The following is a description of a gene set: from publication Chen Y, Wang X (PMID 31504780) Genes predicted to be targets of miRBase v22 microRNA mmu_miR_467f in miRDB v6.0 with MirTarget v4 prediction scores > 80 (high confidence targets). Mouse Gene Set: MIR_467F species: Mus musculus, and this is the list of marker genes: Mapk1, Dmxl1, Lrch2, Atp10b, Ube2h, Rab3c, Cdkl4, Rab11fip3, Tnfrsf11b, Lrrn1, Rab10, Fam43a, Dicer1, Zfp872, Uty, Olfml2b, Mef2d, Rab11fip2, G2e3, Smo, Plekhm3, Chp1, Tcerg1l, Pik3c3, Xrn2, Klhl2, Zbtb41, Foxf2, Hmga2, Rictor, Npat, Pabir2, Rab9, Lrp6, Lrp1b, Rabgap1, Septin9 (septin 9, NCBI Gene Id 53860), Extl3, Smad7, Paip1, Igfbpl1, Tmtc2, Dlat, Wdfy3 (NCBI Gene Id 72145), Hmgxb4, Gfra2, Mmp11, Ccdc82, Fam184a, Zfyve21, Far1, Prkaa1, Parg, Mex3d, Arid4b, Elf3, Gabrb2, Mtfp1, Golph3l, Slc1a2, Ppp4r2, Usp42, Psph, Ulk1, Gucy1a1, Cep192, Hexim1, Usp9x, Naa15, Appl1, Slc28a3, Raph1, Seh1l (NCBI Gene Id 72124), Herc1, Rbfox1, Pitx2, Bbx, Zswim6 (zinc finger SWIM-type containing 6), Snrk, Klf6, Chic1 (cysteine-rich hydrophobic domain 1), Arap2, Hmcn1, Itsn1, Tgfb2, Syt1, Slfn9, Cep135 (NCBI Gene Id 381644), Paics (phosphoribosylaminoimidazole carboxylase, phosphoribosylaminoribosylaminoimidazole, succinocarboxamide synthetase), Secisbp2l, Ube3c, Wee1, Plag1, Zmym6, Clip1, Twist2 (NCBI Gene Id 13345), Trappc10, Ppid, Usp32, Npas3, Tmcc1, Tent4b, Mgam, Nt5e, Fhip2a, Spin1, Rbfox2, Btaf1, Ralgds, Zc3h7b, Pabpc5, Baz2b, Tmem196 (NCBI Gene Id 217951), Zmat1, Ubr1, Zfp871, U2surp, Zfp941, Pde3a, Cxcl16, Mtf2, Ifi204, Dagla, Ogfrl1, Prr12, Ube2d2a, Igfbp1, Cdkn1b, Pigc, Cilk1, Cflar, Gucy1b1, Mapk6, Col1a1, Tle1, Tmprss12, Clstn1, Nova1, Hhip, Cnep1r1, Ube2b, Enpp2, Gorab, Aak1, Mllt10, Nr1d2, Smad6, Zfp280d, Dnali1, Arhgef18 (NCBI Gene Id 319493), Abcd3, Rasef, Cep76 (NCBI Gene Id 76151), Yy1, Hsp90b1, Pde4dip, Tmem33, Eif5b, Adamts5, Tshz3, Slc6a19, Morf4l1, Kcna2, Ino80d, Mrps14, Nedd9, Tecrl, Scp2, Mmd, Mon2, Spock3, Fgfr1, Ctsc, Mcu, Casp8ap2, Vkorc1l1, Rtn1, Pcdh18, Cab39, Ms4a4b, Nfat5, Dgkd, Tsc22d2, Pcdh17 (NCBI Gene Id 77386), Tcf7l2 (NCBI Gene Id 21416), Eif1ad8, Zfp711, Cdh4, Cnot7, Cdc73, Dio3, Txndc9, Trim23, Fbxl17, Nup133, Acyp1, Hectd2, Tasp1, Phf13, Gpm6a, Rbm5, Agtr1b, Kmt2c, Ascl1, Hycc2, Scn2a, Sdad1, Arid1b, Gpr22, Sall3, Rmnd5a, Pkp1, Sdc2, Spred1, Slc38a2, Adamts15, Sfpq, Usp28, Rbbp6, Usp34, Pramel60, Serpini1, Golim4, Lemd3, Eif3e, Stxbp3, Slain2 (SLAIN motif family, member 2), Ddx21, Cast, Synj1, Hnrnpr, Erf, Rb1cc1, Adgrd1, Tc2n, Tle4, Eea1, Pdgfc, Pramel48, Hivep1 (NCBI Gene Id 15271), Homer1, Ctla4, Zfyve16, Jag1, Foxn2, Kdm3a, Grb2, Cks2, Map2, Cabcoco1, Plekhd1, Olr1, Birc6, Tmem170b, Lrif1, Arhgef9, Mbip, Mbnl2, Kif27, Golt1a, Ssbp2, Sbno1, Sh2d4a, Fpgt, Adgre4, Tbr1, Kitl, Fli1, Ss18l1, Hspa14, Pdha1, Fbxo34, Cwc22, Atp2b3, Pcsk2 (proprotein convertase subtilisin/kexin type 2), 1700010I14Rik, Usp25, Rbm27, Malt1, Pum1, Epha5, Lamtor3, Ubtf, Zfp11, Pde3b, Col19a1, Snap29, Slfn8, Myt1l, Pitpnb, Cggbp1, Zfp422, Cxadr, P2ry1, Sh3gl3, Adam9, Pex3, Txlng, Slc10a4-ps, Prkar1a, Hip1, Or51l4, Rras2, Rab14, Casz1, Magel2, Mrpl44, Zic4, Nus1, Arhgap39, Sike1, Snx12, Slc8a1, P2ry12, Pafah1b2, Atad5, Gabrb3, Hnrnpa3, Sos1, Nkx2-1, Dcun1d4, 2310022A10Rik (NCBI Gene Id 66367), Rev3l, Rnf220, Bag4, Prdm15, Tob1, Dido1, Slc4a7, Dock11, Nxt2, Pum2, Ppfia2, Adcyap1, Tgfbr3, Btbd3, Ddx19a, Slc23a2, Zmynd8, Trappc6b, Hs3st1 (heparan sulfate (glucosamine) 3-O-sulfotransferase 1), Gata3, Rab6b